Given this list of marker genes Zmynd15 (zinc finger, MYND-type containing 15), Ppdpf, Bri3, Pin1 (peptidyl-prolyl cis/trans isomerase, NIMA-interacting 1), Fabp5, here is a description of the gene set: studied in species Mus musculus Genes positively differentially expressed in cell type: Langerhans upon treatment with cytokine: APRIL in mouse lymph nodes in vivo. Cytokines mediate cell-cell communication in the immune system and represent important therapeutic targets. A myriad of studies have highlighted their central role in immune function, yet we lack a global view of the cellular responses of each immune cell type to each cytokine. To address this gap, the authors created the Immune Dictionary, a compendium of single-cell transcriptomic profiles of more than 17 immune cell types in response to each of 86 cytokines (>1,400 cytokine-cell type combinations) in mouse lymph nodes in vivo. A cytokine-centric view of the dictionary revealed that most cytokines induce highly cell-type-specific responses. For example, the inflammatory cytokine interleukin-1β induces distinct gene programmes in almost every cell type. A cell-type-centric view of the dictionary identified more than 66 cytokine-driven cellular polarization states across immune cell types, including previously uncharacterized states such as an interleukin-18-induced polyfunctional natural killer cell state. from publication Cui A, Huang T, Li S, Ma A, Pérez JL, Sander C, Keskin DB, Wu CJ, Fraenkel E, Hacohen N (PMID 38057668) Mouse Gene Set: CUI_LANGERHANS_APRIL_RESPONSE_UP